Given this list of marker genes DHPS, U2AF2, ARSF, RPS23, TPST2, ARSA, RWDD1, RPS6, DPH7, SUMF2, ARSB, F8, JMJD7, FN3KRP, GGCX, ASPH (aspartate beta-hydroxylase), DPH5, DPH3, F7, DRG1, RPL27A, BGLAP, ARSL, STS, DPH2, RIOX2, ETF1 (eukaryotic translation termination factor 1), TPST1, ARSK, RCCD1, ARSG, DPH6, F10, JMJD4, EIF5A, PROS1, EEF2, DNAJC24, ARSJ, F9, DPH1, F2, FURIN, PROC, FN3K, ARSI, SUMF1, EIF5A2, JMJD6, OGFOD1, ARSH, ARSD, PROZ, GAS6, KDM8, RPL8, ICMT (isoprenylcysteine carboxyl methyltransferase), RIOX1, DOHH, DRG2, ZC3H15, here is a description of the gene set: Human Gene Set: REACTOME_GAMMA_CARBOXYLATION_HYPUSINYLATION_HYDROXYLATION_AND_ARYLSULFATASE_ACTIVATION Gamma carboxylation, hypusinylation, hydroxylation, and arylsulfatase activation species: Homo sapiens